The following is a description of a gene set: Enables the transfer of sodium ions (Na+) from one side of a membrane to the other. studied in species Homo sapiens Human Gene Set: GOMF_SODIUM_ION_TRANSMEMBRANE_TRANSPORTER_ACTIVITY, and this is the list of marker genes: SLC9A6, SLC4A4 (solute carrier family 4 member 4), ATP1A3, SLC22A1, GPD1L, TPCN1, SLC9B1, SLC5A6, SLC38A7, SLC24A4, SLC24A2, SLC12A1, FXYD3, SLC24A1, SLC17A3, MCOLN3, SLC38A2, TMEM168, ATP1A1, SCN5A, ASIC1, FGF14, SLC9A8, SLC8A2, HCN1, ATP2B4, SLC5A1, SLC4A8, FXYD5, GRIK2, SLC5A11, GRIN1, YWHAH (tyrosine 3-monooxygenase/tryptophan 5-monooxygenase activation protein eta), CNGA3, SLC5A8, SLC9A9, SCLT1, SLC28A2, SLC4A9, SLC13A2, SLC12A2, SLC6A2, SLC13A3, PKD2, CAV3, SLC9A4, SNTA1, GRIK3, FXYD2, FXYD7, SLC1A2, HCN3, SLC10A3, SLC41A3, SLC6A4, GLRX, SCNN1G, TMPRSS3, SCN8A, RSC1A1, C8orf44-SGK3, SLC9C1, SLC6A5, SLC13A5, SLC4A11, P2RX7 (NCBI Gene Id 5027), SLC5A5, SLC38A4, NOS1, NEDD4L, GPLD1, KCNK9, SLC10A2, COMMD1, SLC4A7, ATP12A, SLC5A4, SCN11A, SCN7A, FGF11, SLC6A13, SLC10A5, SCNN1B, SCN4A, SLC10A1, SLC6A6, ATP4A, SCN4B, GRIK1, SLC17A2, KCNK3, SLC17A8, SLC9A1, HCN4, ASIC4, ATP1A2, GRIK4, AGT, SLC6A8, SLC17A4, SLC24A3, SLC6A14, SLC20A2, SLC6A9, FXYD6P3, SLC4A10, PTPN3, ANK3, SLC13A4, CNGA1, SLC38A3, SLC8A1, KCNK1 (potassium two pore domain channel subfamily K member 1), SLC17A7, SLC9A5, MFSD2A, CAMK2D, SLC8A3, TRPM5, SLC34A1, SLC18A2, CHP1, SCN2B, PCSK9, SCNN1D (sodium channel epithelial 1 subunit delta), SLC12A3, SLC38A1, SLC23A1, PKP2, SLC5A9, SLC9A3, SLC9A2, ATP1A4, RANGRF, SLC5A3, SCN3B, SLC6A15, SLC4A5, SCN2A, CNGB1, SLC34A2, ASIC2, SLC1A6, SHROOM2, SLC9C2, SLC5A7, SCN3A, SCNN1A, SGK3, SLC5A2, SLC6A18, SLC5A10, SLC6A11, SLC38A5, SLC1A7, SLC9B2, FXYD1, SCN1A, SLC34A3, FXYD6, TPCN2, SCN10A, ASIC3, SGK2, FGF12, SLC23A2 (NCBI Gene Id 9962), NEDD4, SLC18A1, SLC6A7, SGK1 (NCBI Gene Id 6446), SLC10A6 (solute carrier family 10 member 6), TRPM4, SLC28A3, CNNM4, ASIC5, SLC20A1, TRPM2, PKD2L1, SLC41A1, SLC17A6, FGF13, SLC6A1, SCN1B, SLC17A1, SLC6A20, SLC1A3, SLC6A3, SLC13A1, SLC6A12 (NCBI Gene Id 6539), SLC1A1, SLC8B1 (solute carrier family 8 member B1), HCN2, SLC10A4, TRPV3, SLC5A12, SLC24A5, SCN9A, ATP1B1, SLC28A1, MCOLN1, NALCN, SLC9A7, FXYD4, GRIK5, SLC29A1